The following is a description of a gene set: studied in species Homo sapiens Human Gene Set: GOBP_PURINE_RIBONUCLEOSIDE_SALVAGE Any process which produces a purine nucleoside from derivatives of it, without de novo synthesis., and this is the list of marker genes: PNP, PGM2, HPRT1, APRT, ADK, MTAP, PRTFDC1